Given this list of marker genes MGAT1, PMVK, MVK, EBP, HMGCS1, LDLR, DHCR24, SQLE, TM7SF2, IDI1, FDFT1, MVD, APOA4, LBR, NPC1L1, SAR1B, FDPS, LSS, FABP2, HSD17B7, APOB, SC5D, ABCG8, DHCR7, MTTP, ACAT2, CYP51A1, NSDHL, APOA1, ABCA1, ABCG5, HMGCR, SLC27A4, MSMO1, CD36, DGAT1, here is a description of the gene set: Enterocyte cholesterol metabolism studied in species Homo sapiens Human Gene Set: WP_ENTEROCYTE_CHOLESTEROL_METABOLISM